Given this list of marker genes Ido1 (indoleamine 2,3-dioxygenase 1), Pde5a, Adora2b, Il4, Cyp19a1, Tnf, Cx3cr1, Foxp3, Lta, Il10, Tnfaip3, here is a description of the gene set: Any process that modulates the frequency, rate, or extent of a chronic inflammatory response. Mouse Gene Set: GOBP_REGULATION_OF_CHRONIC_INFLAMMATORY_RESPONSE species: Mus musculus